Given this list of marker genes Mc2r, Mrgpra4, Npy1r, Qrfpr, Npy5r, Npsr1 (neuropeptide S receptor 1), Gpr139, Ntsr2, Tacr3, Cckbr, Gpr83, Prokr1, Ntsr1, Sstr1, Npffr2, Nmur2, Prlhr, Tacr2, Gpr171, Npy4r, Prokr2, Galr3, Galr1, Sstr2, Gpr143, Sstr5, Sstr4, Nmbr, Mrgpra1, Tacr1 (NCBI Gene Id 21336), Brs3, Gpr165, Sstr3 (NCBI Gene Id 20607), Gal, Npy6r, Gpr37, Npbwr1, Galr2, Nmur1, Npy2r, Kiss1r, Oprm1, Grpr, here is a description of the gene set: studied in species Mus musculus Mouse Gene Set: GOMF_NEUROPEPTIDE_RECEPTOR_ACTIVITY Combining with a neuropeptide to initiate a change in cell activity.